The following is a description of a gene set: species: Homo sapiens Genes predicted to be targets of miRBase v22 microRNA hsa-miR-625-5p in miRDB v6.0 with MirTarget v4 prediction scores > 80 (high confidence targets). Human Gene Set: MIR625_5P from publication Chen Y, Wang X (PMID 31504780), and this is the list of marker genes: RAG1, RSPO2, NSL1, KRT23, SMUG1, KLHL13, WBP4, MPZ, ZNF527, PHYH, NSD1, PCDHB13, ANGEL1, BRWD3, RAD51D, POU3F2, ZDHHC15, LHX6, SPIN1, REG3A, STX8, STC1, PPP1R3C, SRGAP1, CNN2, RABGGTB, MCC, IGF2BP1 (NCBI Gene Id 201194), TBCEL, DVL3, CHD6, ATAD2B, CASQ1, POLR1D, SPRY4, GATAD2B, EPB41L4B, MTSS2, ZNF395, SENP6, ATXN1, FAS, SEPTIN6, SLC6A17, GYS2, IFFO2, DDX17, CTBS (chitobiase), UBE2N, SUMO2, ZNF32, MBD2, PIGG, NOS1, BCLAF1, C1orf198, TTPAL, THUMPD2, MYCT1, SERTAD2, DAPP1, PVALB, ASB11, IQSEC3, HECW2, GHRH, TLNRD1, FBN1, PHLDA3, ARID2, MACO1, P2RY4, SEMA6A, PPP2R1A, LETM1, AHCTF1 (NCBI Gene Id 442770), POLR2M, PRPF38B, AVPR1A, CALU, STXBP4, IL18BP, PPP6C, SEC24A, CRYZ, TES, C5orf15, UBE2K, RIMKLA, TXK, PTBP3, APLNR, ABI2, ZNF519, PTGER3, PLCXD3, KLK10, IP6K3, ZNF444, TSHZ2, ARIH2, PEX5, WASF1, CBX5 (NCBI Gene Id 23468), NXPH2, PPP2R2D, SOX7, NFIX, ACTB, ZSWIM4, MFN2, RAB33B, SNPH, SUMO4, ORMDL3, EID2, PKM, TSPAN11, HNRNPAB, MAJIN, CYB5B, TNK2, CLDN11, ASAH1 (N-acylsphingosine amidohydrolase 1), ZNF629, STIM1, ZNRF2, CCDC33, MECP2, PLEKHH1, AMOT, GRIA4, KRT1, MGST2, GCOM1, EPB41L1, RASL11B, SCIMP, SPICE1, FLOT2 (NCBI Gene Id 2319), ATAT1 (alpha tubulin acetyltransferase 1), ATXN2L, OVOL2, NECTIN1, HOXB5, PXYLP1, ITSN1, SESN3, CASKIN2, LEFTY2, GABRP, DCLK1, TBC1D7, UBAP2L, ERVFRD-1, PCDHGA6, NBN, KLHL28 (NCBI Gene Id 54813), HMGB3, PMEL, KALRN, CEBPG, SHISAL1, PDE1C, ELOVL2, GIMAP1, WASHC4, G3BP2, ARL5B, DUSP8, NOVA2, HS2ST1, WIZ, PTPRS, IL17D, PABPC4, SNX3, NFASC, CCDC148, PTPRJ, NAPA, JAZF1, ATP10B, C2CD5, SPAG9, CASTOR2, MXD1, RNF10, TTC39C, SEMA3D, PCM1, MPZL2, MEX3A, C5orf24, REEP1, SPOCK1, SCUBE3 (NCBI Gene Id 222663), GSPT1, RBFOX2, FLRT1, CHAF1A, UBE2R2, KATNAL2, ZNF275, NEDD9, INO80D, PPT2, LIX1L, ADAR, PAG1